Given this list of marker genes Psmb7, Nek11, Psmc4, Psmb4, Csnk1a1, Psmb6, Psma7, Chek2, Csnk1e, Psmd1, Mapk14, Psmc1, Psma5, Psmd13, Psmc2, Psmd6, Psma2, Ubb, Psma6, Psma3, Psmc5, Mapk11, Psmb5, Psmc3, Psmc6, Psma4, Rps27a, Psmd12, Cul1, Psmd7, Psma1, here is a description of the gene set: electronically inferred by orthology from the curated human pathway part of: G1/S DNA Damage Checkpoints This event has been computationally inferred from an event that has been demonstrated in another species.<p>The inference is based on the homology mapping from PANTHER. Briefly, reactions for which all involved PhysicalEntities (in input, output and catalyst) have a mapped orthologue/paralogue (for complexes at least 75% of components must have a mapping) are inferred to the other species. Reactome Pathway: p53-Independent G1/S DNA Damage Checkpoint studied in species Mus musculus